Given this list of marker genes HSD11B2, CYP11B2, TACR3, ACE, ADORA1, TPM1, GLP1R, ENG, WNK1, TACR1, ADRB1, AVP, NPFF, ADRA1A, RARRES2, CARTPT, MIR17, NMU, TBXA2R (thromboxane A2 receptor), GRIP2, PTPN1, AVPR2, OXTR, MANF, OXT, CYBA, ID2, ADRA2B, AVPR1A, SPX, DRD5, ADH5, OR51E2, TAC3, RHOA, NR2F2, QRFP, here is a description of the gene set: Any process in which the force of blood traveling through the circulatory system is increased. species: Homo sapiens Human Gene Set: GOBP_POSITIVE_REGULATION_OF_BLOOD_PRESSURE